Given this list of marker genes RSPO3, WNT5A, SMURF1, RHOA, SMURF2, WNT7A, CSNK1D (NCBI Gene Id 1453), WNT3A (NCBI Gene Id 89780), FZD7, FRZB, DVL2, FZD9, RNF213, RYK, ANKRD6, DAB2, MED12 (NCBI Gene Id 9968), CSNK1E, FZD3, SFRP4, IFT80, ARHGEF19, CELSR3, SPEF1, LBX2 (NCBI Gene Id 85474), CELSR2, TMEM67, PLEKHA4, CELSR1, TIAM1, DAAM1, NLK, NKD1, RAC1, MAGI2, PRICKLE2, CCDC88C, CTHRC1 (collagen triple helix repeat containing 1), WNT7B, VANGL2, CDC42, DVL3 (dishevelled segment polarity protein 3), FZD6, PRICKLE1, WNT5B, SFRP2, DACT1, FZD1, DKK1, ABL1, FZD4, WNT9B (Wnt family member 9B), FZD10, WNT11, MYOC, ZNRF3, SFRP1, VANGL1, FZD5 (NCBI Gene Id 81561), SFRP5, NPHP3, DVL1, FZD8, GPC3, MKS1, DAAM2, MLLT3 (NCBI Gene Id 4300), WNT4, FZD2, here is a description of the gene set: Human Gene Set: GOBP_NON_CANONICAL_WNT_SIGNALING_PATHWAY A type of Wnt signaling pathway in which Wnt binding to its receptor on the surface of a target cell results in the by propagation of the molecular signals via effectors other than beta-catenin. studied in species Homo sapiens